Given this list of marker genes H2AC4, H3C4, H4C11 (H4 clustered histone 11), H3C7, H2BC4, H4C16, H2AC7, H2BC13, H4C3, KPNB1, H2BC15, ORC6, ORC2, H3-3A, H2AC20, H2BC1, H2BC11, H3C10, H4C13, ORC5, H3C6, H2BC21, H3C2, H2AC18, H2BC5, H4C6, H2BC12L, H3C14, H2BC6, H4C12, ORC3, H2AJ, H2BC17, H4C8, H4C4, H3C15, H2AZ2, H3C3, H4C15, H2AC8, H4C14, H2BC3, H3C11, KPNA1, H2BC26, H2AX (H2A.X variant histone), H2BC8, H2BC10, H2BC14, H3C1 (H3 clustered histone 1), H4C2, H4C5, H4C9, H3C8, H3C12, H2BC12, H2AC6, H2AB1, ORC4, H3C13, H4C1, H2BC9, KPNA6, H3-3B, H2AC14, H2BC7, ORC1, H2AC19, here is a description of the gene set: Assembly of the ORC complex at the origin of replication Human Gene Set: REACTOME_ASSEMBLY_OF_THE_ORC_COMPLEX_AT_THE_ORIGIN_OF_REPLICATION studied in species Homo sapiens